The following is a description of a gene set: species: Homo sapiens from publication Chen Y, Wang X (PMID 31504780) Genes predicted to be targets of miRBase v22 microRNA hsa-miR-513b-5p in miRDB v6.0 with MirTarget v4 prediction scores > 80 (high confidence targets). Human Gene Set: MIR513B_5P, and this is the list of marker genes: GPR85 (NCBI Gene Id 54329), TRUB1 (NCBI Gene Id 170561), HOXA10 (NCBI Gene Id 3206), HNRNPK, LHFPL2, LIPI, DNER, MESP1, EML4, METTL15, SF3A1, BMPR1A, PDS5B, ZYG11B, PSD3, ZDHHC14, PPP1R14C, WWTR1, LYZL4, PDE12, ZNF512, TTC3, GRID1, COX7A2, TMEM196, USP25, ISOC1, ASPH, ARHGAP42, CHD2, S100PBP, HAT1, BMF, IHO1 (NCBI Gene Id 339834), CPEB3, HTR2C, LRRC2, PGRMC1, TBL1XR1, PAPPA2, FAM135A, SH3BGRL2, SAMTOR, LRRC58, ZBTB41, ABHD17B, SNX2, AHI1, EBF2, SSR3, RP2, VEGFD, BCL2L11, ADAMTSL1, GIMAP4, NAV3, USP21, SPTLC2, USP44, GBX2, CLASP2, DLX1, TMCC1, PTGS2, CCL11, ABCE1, MED26, SLC18A2, CCPG1, RBM27, MGAT4A (alpha-1,3-mannosyl-glycoprotein 4-beta-N-acetylglucosaminyltransferase A), CNTNAP2, NCOR1, MTCL1, RHOA, INSM1, ZNF419, RNF20, ADAM28, MSI2, STAG1, TRAPPC10, SNRPF, CPNE8 (NCBI Gene Id 144402), KRTAP9-9, GNB4, ZIC2, TBCEL (tubulin folding cofactor E like), CHMP5, ELAVL1, RABGEF1, UCHL3, MDH1, BLCAP, CBLL1, PKIA, WWC3, KHDRBS3, FUT9, CDYL2, PPP4R3A, PTPN4, SNRPN, TCEAL9, CNKSR2, BCL11B, SPRY2, ZFHX4, DLC1, IKZF2 (NCBI Gene Id 51173), SOS1 (SOS Ras/Rac guanine nucleotide exchange factor 1), SYNPO2L, METAP1, DR1, NECAB2 (NCBI Gene Id 54550), DLG3, PPP2R3A, BSN, CRMP1, LIN28B, TMEM39A, AMD1, LEMD3, SPATA2, KRTAP22-2, RALGPS1, GTF2A1L, ARFGAP3, TRIB2, P3R3URF-PIK3R3, GAPVD1, NEXMIF, USP51, CERT1, SLC17A6, PKD1L1, IVNS1ABP, FBXW2, ZNF704, C2orf69, TOGARAM1, E2F5, APOL4, AGO4, PPP1R3E, SPRYD7, SCML4 (NCBI Gene Id 256380), HNRNPU, TRAF3, CLTC, SHPRH, SALL2, SLC39A9, CASQ1, PAK1, PRDM16, NKRF, CXADR, ZEB2, RYBP, STON1-GTF2A1L, JPT1, INPP5F (NCBI Gene Id 22876), TCF7L2, PPARGC1B, RASGRP2, NEK7, EHF (ETS homologous factor), ZBTB43, BDNF, MAN1A1, HDX (NCBI Gene Id 139324, highly divergent homeobox), ZIC3, DMD, CACNB4, LRIG2, LHX8, FEM1C, CLVS2, KL, SLC10A7 (solute carrier family 10 member 7), SH3GLB1, GATA2, U2SURP, GBP4, GRPR, ARID4B, GMFB, DIPK2A, RMND5A, DNAAF4, NIN, CCDC15 (NCBI Gene Id 80071), FAM131B, TNKS2, LURAP1, SNX25, XIAP, REV1, MED6, TOMM20, RCOR1, VAPA, GABPA, PRPF39 (NCBI Gene Id 81951), URI1, CALCR, MKLN1, CRTC3, SYT4 (NCBI Gene Id 6860), ADCYAP1, ARHGAP5, E2F6, CWC22, SLX4, SMIM13, SOX6, RNGTT, SCN5A, BPIFC, CDK19, EEA1, MTDH, ADGRG6 (NCBI Gene Id 57211), SNAP25, TLE1, PTPRR, AGFG1, GABPB1, ZZZ3, TET2, PTPRK, PTPN14, EGLN1, VHL, ARID4A, PPM1E, KIF2A, CHN2, ZFP36L2, ERBB4, SENP7, NEGR1, EIF1B, MRPL19, BPNT2, C1orf52, SLC38A1, DNAJA2, WEE1, SLC49A4, SV2B, MOSPD1, TSPAN7, ARNT2, VEGFC, CNTN1, HYCC2, MAP3K20, ARID2, DHRS9, TBX3 (T-box transcription factor 3), IRF2, KCNMA1, BTG1 (NCBI Gene Id 694), TMEM64, SNURF, SEL1L, TIMM8A, FSTL5, ACVR2A, SLITRK4, CCNYL1, DCAF10, TFAP2A, IMPACT, CACNA2D1, ANKS1B, TNFRSF19, FGFR1OP2, ATF2, TNPO2, SRSF4, PDE10A, NHS, TENT5A, TMEM192, CPSF6, GCH1, MND1, PIK3R3, ZNF736